The following is a description of a gene set: Mouse Gene Set: chr1H1 species: Mus musculus, and this is the list of marker genes: Gm7430, Astn1 (astrotactin 1), Cryzl2, Mir1843b, Gm34423, 1600012P17Rik, Gm37294, Gm31256, 4930562F07Rik, Sec16b, Tnr, Gm37679 (predicted gene, 37679), Pappa2, Brinp2, Cop1, Gm7412, Mir488, Gm15486, Gm10530, 4930562F17Rik, 2810025M15Rik, Rasal2, Gm4953, Gm24719, 4930523C07Rik, Gm6058